Given this list of marker genes ACSBG2, ELOVL5, ACSL1, ACSL4, PPT1, ELOVL6, SLC27A2, HSD17B12, ELOVL2, ACSBG1, ACSL5, HACD2 (NCBI Gene Id 9199), ELOVL7, ACSL3 (NCBI Gene Id 55484), ACSL6, ELOVL1, FASN, ELOVL4, TECR, ACSF3, CBR4, HACD1, ACAT1, PPT2, HTD2, GCDH, ACACA, ELOVL3, here is a description of the gene set: studied in species Homo sapiens The chemical reactions and pathways resulting in the formation of a fatty-acyl-CoA, any derivative of coenzyme A in which the sulfhydryl group is in thiolester linkage with a fatty-acyl group. Human Gene Set: GOBP_FATTY_ACYL_COA_BIOSYNTHETIC_PROCESS